Given this list of marker genes FGF8, FGF4, FGF2, FGF1, FGF17, FGF6, FGF23, FGF9 (fibroblast growth factor 9), FGF20, FGF5, ANOS1, GIPC1, FGFR1, TGFBR3, here is a description of the gene set: species: Homo sapiens Human Gene Set: REACTOME_FGFR1C_LIGAND_BINDING_AND_ACTIVATION FGFR1c ligand binding and activation